Given this list of marker genes Slc27a1, Slco2a1, Slco1a4, Slc35c1, Slc35a1, Slc29a1, Slc35b2, Slc25a4, Slc28a1, Slc35b4, Slco4a1, Slco2b1, Slco1c1, Lcn9, Pdzd11, Slco3a1, Avp, Slc27a6, Slc25a5, Slc35a2, Slc35d1, Slc35d2, Slc5a6, Slc28a2, Apod, Slco4c1, Slc29a3, Slc27a4 (NCBI Gene Id 99453), Slc35b3, Arl2, Slc33a1, Slc29a4, Slc35a3, Slc28a3, Slc16a2, Slc29a2, Lcn12, Arl2bp, Slco1b2, here is a description of the gene set: Mouse Gene Set: REACTOME_TRANSPORT_OF_VITAMINS_NUCLEOSIDES_AND_RELATED_MOLECULES studied in species Mus musculus Transport of vitamins, nucleosides, and related molecules